Given this list of marker genes FAM216B, NAT8, RAP1A, POLR3A, RAB30, MAPK8, ING1, ACOT11, TCF12, OPRM1, MAPKAPK5, PHF21A, SLC30A7, MPI, RETREG2, MAPK6, GPD1, BTBD7, HIF1A, SLC1A2, EVX1, NFX1, SOD2, IKBKE, SRPK1, DUSP10, NTNG1, SNX30, CBLN3 (cerebellin 3 precursor), KIAA1549, E2F4, LSP1, SURF4, GAS7, TFDP2, SCUBE3, ZDHHC9, ABCD1, RBM12, FBXO32 (NCBI Gene Id 114907, F-box protein 32), SZRD1, RAP1B, KCNH7, TTYH3, PCGF6, TSHZ1, CIT, RAB43, MCM6, HDGFL3, SRI, LPIN3, PIGU, EFNB1, PXN, SIGLEC15, SPTY2D1, CFAP44, HSD17B12, LTB4R2, SLC5A3, CHD2, FAM76B, BCORL1, HIPK1, PTPRK, SPIN2B, GTF2A1, FAM210B, RIMS3, ADCY1, FRS2, TCF20, NCS1, CABLES2, IGF2R (insulin like growth factor 2 receptor), SPIN2A, NOXRED1, SLC6A6, NRK, KMT2A, AFDN, KIF6, PPP1CC, PLD5, MLEC, YOD1, LRRTM2, PSTPIP2, SULF1, SLC43A2, DNAJB6, SLC39A8, INSYN2A, PTPN1, RAPGEF5, DHCR7, SV2B, NCOA2, MMP24, NKX2-1, HTRA1, SLITRK3, RPS6KA5, DLG2, SETD7, SERPINF2, MTCL2, RASA1, CNOT2, ANKRD60, CDS1 (NCBI Gene Id 1040), SMU1, GRIK3, GPRASP1, NISCH, here is a description of the gene set: Genes predicted to be targets of miRBase v22 microRNA hsa-miR-9851-5p in miRDB v6.0 with MirTarget v4 prediction scores > 80 (high confidence targets). from publication Chen Y, Wang X (PMID 31504780) studied in species Homo sapiens Human Gene Set: MIR9851_5P